The following is a description of a gene set: Human Gene Set: HP_ABNORMAL_IMMUNE_SYSTEM_MORPHOLOGY Abnormal immune system morphology species: Homo sapiens, and this is the list of marker genes: NFKB2, PNPLA2, GATA1, CD40LG, PRKAR1A, DDR2, G6PD, SRP19, TNFRSF1A, SH2D1A, RPL35A, PRDX1, RAC2, ATP11A, EXTL3, PSTPIP1, MAN2B1, LRRC8A, TAFAZZIN, USB1, DNMT3B, FANCD2, MPL, VPS33A, ICOSLG, POMP, TDP2, RAD51, AP3B1, HLA-DRB1, SOS1, ERCC3, FBXW7, PTPN6, CUBN, HTRA2, RAG2, RTEL1, HAVCR2, IKBKB, SARS2, COG4, IL2RG, FCGR3A, PTPRC, PSENEN, BLOC1S6, MAP3K14, SPI1, C4A, TCF4, RASGRP1, MMAA, NBN, FTCD, TLR7 (NCBI Gene Id 51284), ATP6AP1, IDH1, DUT, MICU1, NAF1, SLC30A7, MYH9, SKIC2, NLRP1, ENG, NCKAP1L, HEATR3, RPL35, SOS2, PRKDC (NCBI Gene Id 5591, protein kinase, DNA-activated, catalytic subunit), WAS, TYMS, MEFV, ADA2, IL2RB, CDCA7 (cell division cycle associated 7), RPS15A, IL36RN, TP53, SETBP1, MLLT10, NCAPG2, CTPS1, KIT (NCBI Gene Id 5086), CD8A, LAT, STAT2, NUP214, IFIH1, CYBA, ELANE, EIF2AK3, GJB2, BLNK, MCM10, ETS1, RPS17 (ribosomal protein S17), SRSF2, BAX, FCGR2A, TERC, STAT4, BTK, FDX2 (NCBI Gene Id 2143), MCM4, PRIM1, CASP8, GINS1, IRF5, IKBKG, PLCG2, USP48, ASAH1, MAP2K1, RRAS2, PTPN11, ZAP70, IL2RA, LCK, ZNFX1, STAT6, RFXANK, DIAPH1, NPC2, GATA2, TNFRSF1B, PIGL, GTF2H5, AK2, IGHG1, CD3G, TGFB1, LCP2, WRAP53, SLC17A5, LPP, OAS1, FOXN1, SPINK5 (serine peptidase inhibitor Kazal type 5), SRP54, DOCK8, CASP10, NUTM1, IL6R, IL37, RPL31, RAP1B, KRAS, CAPN3, IFNG, TRIP13, LSM11, HMGCL, FANCM, PPT1, RNASEH2C, TET2, RABL3, PIK3R1, ITGAM, SLC39A7, CIITA, CD81, NHP2, SLC35A1, LIPA, STN1, TONSL, KLHDC8B, WIPF1, RFXAP, PALB2, MTRR, RAB27A, IRF2BP2, IRF1, VPS13B, CTNNBL1, ANAPC1, MDM2, APOE, TNFSF4, GJB6, MALT1, STING1, NCF2 (neutrophil cytosolic factor 2), SF3B1, PMM2 (phosphomannomutase 2), BUB1B, RPS26, RNF31, JAK1, SEC61A1, DNASE2, RPL8, PKHD1, MYC, TFRC, BRAF, SGCG, NOP10, KMT2D, CPA1, CA2, SCARB2, ADAMTS3, TRNT1, APC2, RIPK1, STIM1, CEBPE, TLR8, H4C9, IL10RA, PML, SCN11A, ICOS, MSH2, ALAD, CARD10, EVC, SMAD4 (SMAD family member 4), MTR, SREBF1, IRAK4, TTC7A, CD40 (CD40 molecule), SAMD9L, MVK, CXCR2, TNFSF12, TLR3, ADAR, CAMK2B, SRP68, RECQL4, CLN3, LZTR1, FLT3, RASA2, NUMA1, MPLKIP, USP8, CD27, IRF8, EPB42, DNASE1, STAT5B, TARS1, PI4KA, RPS27, GLB1, SLC29A3, PRSS2, SPP1, PRKCD, CYBB, RPL27, NCF4, FCHO1, DDX41, REL, STAT3, FCGR3B, AP3D1, MMACHC, HBB, FBXL4, LYST, HLA-B, RPS10, PDGFRA, PTEN, DKC1, SHARPIN (SHANK associated RH domain interactor), FUCA1, FANCC (NCBI Gene Id 2176), BCL11B, LIG1 (NCBI Gene Id 3978), OSTM1, LBR, SLC46A1, IL1RN, NR3C1, TYROBP, ABCB4, IL7R, RAD51C, SLX4, SASH3, KNSTRN, RPS29, PIGA, CLCN7, CARD11, IL6ST, MBD4, MSN, PDCD1, LPIN2, UBE2A, RPS19, ACP5, RPL5, SGPL1, PNP, TRAC, SPINK1, MDM4, ITCH, F13B, KIF11, ADH5, LEP, ANKRD26, ABCD4, POLD3, NTRK1, NCF1, CCBE1, CD19, RBCK1, LMNB2, MAGT1, NHEJ1, XRCC4, MYD88 (MYD88 innate immune signal transduction adaptor), FANCI, ATRX, CTLA4, CHEK2, GSS, AGR2, FOCAD, GPI, AGA, HYOU1, LRBA, DLX3, CD70, ITK, PCCB, IPO8, EP300, LIG4, CHD7, CHIC2, RPL9, CYBC1, SMARCAL1 (NCBI Gene Id 50485), RNU4ATAC, CD28, RAF1, RFX5, CTSC, FANCB, DLL4, PSMB10, CYP27B1, TICAM1, SPPL2A, ITGB2, DNAJC21, POLD1, XRCC2, PSMB9, SPRED2, MAX, CD3E, FANCA, SAT1, ZBTB24, CEP57, TNIP1, GNB1, ARHGAP31, SLC37A4, ADA, AP1S3, NFKBIA, B2M, EOGT, ABHD5, TAL2, JAK2, BLK (BLK proto-oncogene, Src family tyrosine kinase), RHOH, LMBRD1, BTNL2, NFKB1, TFR2, ZPR1, DOCK2, MPO, CASR, NPC1, RELB, BLM, ISCU, ARHGAP26, UNC93B1, TPP2, VPS45, CD4, SCO2 (NCBI Gene Id 9997), MECOM, ALG12, IKZF3, CFTR, BANK1, PRTN3, TRPV6, NLRP12, PTPN22, IKZF1, NRAS, ACVRL1, FNIP1, ELF4, RRAS, IVD, MLH1, SH2B3, SLC19A1, DNMT3A, RAG1, RNU7-1, FAT4, RIT1, UNC13D, CLN5, CASK, ERBB3, ERCC6L2 (NCBI Gene Id 56959), CR2, TBX21, FIBP (NCBI Gene Id 9158), RMRP, AMN, PALLD, NPM1, ACAT1, CDKN2A, BRIP1, IGHG2, MS4A1, PIK3CG, GTF2E2, NHLRC2, SLC7A7, ARPC1B, DYNC2LI1, TNFAIP3, CARMIL2, SH3GL1, RBM8A, UHRF1, STK4, RARA, RPS24, ZNF699, EPG5, SCN9A, PHEX, JAZF1, CARD9, IFNGR1, LAMTOR2, ARHGEF1, UNC119, BRCA2, CBL, TCF3, CTRC, ARPC5, BCL10, IRAK1, SBDS, SMPD1, NLRP3, IGKC, BRCA1, VANGL1, NAE1, EFL1, TTI2, FERMT3 (NCBI Gene Id 83706), PCCA, NEU1, GFI1, PACS2, SAMD9, FIP1L1, JAGN1, RPL15, SYK, TNFRSF13C, MGAT2, DMP1, DCLRE1C, FUT8, BUB1, RPL11, MYSM1, LACC1, TCIRG1, UBE2T, IGLL1, OTUD5, CTC1, RNASEH2A, PRSS1, OTULIN, ACD, GLI1, FASLG, PRF1, HLA-DPA1, BCOR, IL17RA, ETV6, RBPJ, MPEG1 (macrophage expressed 1), CXCR4, TMEM147, RPS7, TBXAS1, SMARCD2, TREX1, JAK3, RPS14, PIK3CA, NSMCE3, CDH23, BUB3, ORAI1, PICALM (NCBI Gene Id 8301, phosphatidylinositol binding clathrin assembly protein), DEF6, UROS, CRELD1, APC, F13A1, GBA1, FANCF, RNF113A, CORO1A, ABL1, SALL4, TSR2, STAT1, TCN2, RPS20 (NCBI Gene Id 6224), ZBTB16, FGF23, TINF2, PRKACB, RUNX1, PRKACA (protein kinase cAMP-activated catalytic subunit alpha), HSCB, RFWD3, MECP2, TBK1, NDUFA6, ENPP1, C1GALT1C1, XIAP, IL10RB, THPO, CREBBP, ZNF341, ASXL1, RPL18, BACH2, ATM, FANCG, SLC35C1 (solute carrier family 35 member C1), MAD2L2, ERCC2, GPR35, TERT, PXK, CD79B, NABP1, TNFRSF13B, FAS, EVC2, IL7, SPRED1, TAL1, FOXP3, DOCK11, RB1, TRAF3, NLRC4, RPS28, TBX2, LYN, STXBP2, SCN10A, NSD1, CLPB, CSF3R, NOTCH1, G6PC3, FGFR3, CEBPA, STX11, C4B, TREM2, SLC27A4, PIK3CD, LEPR, CALR, DCLRE1B, FMO3 (flavin containing dimethylaniline monoxygenase 3), PPIL1, EPX, NSUN2, ERCC4, FANCE (FA complementation group E), SEMA4D, HLA-DPB1, BCR, PARN, DOCK6, ATP6AP2, SFXN4, FCGR2B, HELLS, STS, TOM1 (NCBI Gene Id 10043), SOCS1, CDC40, CYP26C1, GALE, TBL1XR1, PSMB4, MRAS, AARS1, IL21, UBE2L3, PGM3, CD79A, CARS1, SLF2, HAX1, FANCL, MNX1 (NCBI Gene Id 7987), MST1, MTHFD1, TNFRSF9, RPL26, WDR1, NBAS, MMAB, CBLB, KDM6A, IVNS1ABP, CDSN, CD247, BRD4, RNASEH2B (ribonuclease H2 subunit B), IL10, SKIC3, CYP2R1, SAMHD1, PSEN1, CD3D (CD3 delta subunit of T-cell receptor complex), KIAA0319L, NF1, RPA1, IGHM, MMUT, SP110